The following is a description of a gene set: Human Gene Set: MEBARKI_HCC_PROGENITOR_FZD8CRD_UP studied in species Homo sapiens from publication Mebarki S, Désert R, Sulpice L, Sicard M, Desille M, Canal F, Dubois-Pot Schneider H, Bergeat D, Turlin B, Bellaud P, Lavergne E, Le Guével R, Corlu A, Perret C, Coulouarn C, Clément B, Musso O (PMID 27191501) Transcriptome of human HepaRG hepatocellular carcinoma liver progenitors in responses to a WNT3A-enriched microenvironment and dissection of pathways dependent on _-catenin and/or blocked by the SFRP-like Wnt inhibitor FZD8_CRD. Methods: Liver progenitor cells were incubated in a WNT-enriched microenvironment for 72hrs (200 ng/ml mouse recombinant purified Wnt3A from R&D Systems). Gene pathways dependent on downstream _-catenin were studied by _-catenin knockdown with specific siRNA. Gene pathways blocked by extracellular SFRP-like Wnt inhibitors were studied by co-incubating cells with recombinant purified FZD8_CRD (300 ng/ml, from R&D Systems). Independent culture experiments performed in triplicate include untreated cells or cells incubated with scrambled siRNA or with _-catenin-specific siRNA or with FZD8_CRD, alone or in combination with Wnt3A., and this is the list of marker genes: HJURP, HERC5, KIF24, FHDC1 (NCBI Gene Id 85462), ZWINT, BCL11B, BATF3, ILDR2, FAM111A, PLD5, WFDC21P, CENPE, FOXM1, FANCB, TUBBP2, PBK (NCBI Gene Id 55886), CHAF1A, NCAPD3, E2F1, CCR7, ENSG00000187951, RDM1, PSG2, CDKN3, H3C7, CKLF, MYB, CDC25B, RRM1, H2BC21, CIT, TUBG1, MAD2L1, OXR1, BLM, CDKL1, BARD1, VLDLR-AS1, KIFC1, NUP93, MBOAT1, NRGN, NLRP5, CACYBP, GINS2, SUV39H1, NCAPG2, DMBX1, ORC6, CDC6, TCF12-DT, UBASH3B, TMEM40, AURKB, CCNA2, CEP57L1, SKA1, PPP4R4, TRPA2P, UGCG (NCBI Gene Id 7357), POLE2, SASS6, MCUB, GDF15, BUB1, HMGB2 (NCBI Gene Id 3148), CRACDL, KIF20A, NIBAN1, PLAT, NR2F1-AS1, PHF19, TUBA1C, INPP5J, LINC00942, TP73, PTTG2, KPNA2, LRRC3, CKS2, EZH2, TAF1A, SAE1, PRIM2, DCLRE1B, BUB1B, LINC01704, ALG10, NEMP1, OIP5, RAD18, KNSTRN, DIAPH3, PAMR1, CCSAP, CSPG5, NCAPG, CCN3, PARD6G, WRAP53, NDE1, KIF15, TPX2, TMPO-AS1, ADORA2B, GNG12, GAREM2, SLC37A2, FKBPL, THSD1, RAD54L, MCM10, LRRC45, NSD2, GPSM2, HOXC9, RANBP20P (RAN binding protein 20 pseudogene), CKAP2L, PGM2L1, SEPTIN5 (septin 5), ADAM12, FBXO5, DNAJC9, KREMEN2, KIF2A, TRIM55, PHLDB1, FANCD2P2, PLK1, MEX3B, RNASEH2A, H4C4, ORC1, BRCA1, TIPIN, FAM72B, DDX11L2, TEDC2, SMS, SH3GL3, TLR6, CDC45, LRRIQ1, LINC02984, LINC01638, MTBP, TRAIP, LYPD6, TUBB8B, ATAD2, FANCM, ADAMTS5 (NCBI Gene Id 11096), PLEKHO1, TNFRSF8, SMTN, ARHGEF2, AK5, C10orf90, PSMC3IP, THAP10, PHTF2, PTTG1, ETV5, MTFR2 (NCBI Gene Id 113115), KIF2C, H4C14, BNC2, NUF2, SLC7A5, CDK2, LINC01173, ANXA3, ID3, CENPI, KMT5AP1, TAF5L, RFC2, ENSG00000266088 (novel transcript), LINC01111, CENPL, HNRNPDL, HASPIN, LMF2, TUBB6, CREB5, TOP2A, DDIAS, ESPL1, PACC1, FEN1P1, ARID3A, IL11, SEPTIN3, C4orf46, RGS9, TYMS, RNF7P1, VIM, SPC24, CKS1B, JPT1, ENSG00000288781, BRCA2, AUNIP, PLK4, H4C5, DEFB103B, SLC19A1, INCENP, MPHOSPH6, CENPP, PARPBP, H2AC10P, LOXL1, CENPO, CCNG2, KIF20B, PRMT2, TLE3, SCRN1, ARHGAP23P1, VRK1, DNMT3B, NUSAP1, MCM5, RCC2, TMSB15B, MYLK2, DEPDC1B, CHEK2, GPRIN1, FANCC (FA complementation group C), RANBP1, FIRRM, TK1, NUP155, UBE2T, H2AC16, H2AX, PANX2, CDCA4, CRISPLD2 (cysteine rich secretory protein LCCL domain containing 2), GAD1, NES, STIL, ATRIP, CASQ1, CDC20, LOXL3, ENSG00000289047, NECTIN1-DT, SPDL1, PRC1, TEDC1, ADGRB2, H2AC17, STXBP5, PSG9, MIS18BP1, H2BC7, ZNF669, SOCS2-AS1, SPTB, RRM2, LAYN, VEGFC, SLC5A11, MCM2, EXO1, CHRNA5, WDR1, C21orf58, PCMT1, C10orf88B, TICRR, HAUS8, RGS12, POLQ (DNA polymerase theta), UBE2SP2, E2F8, REEP1, C9orf40, CCDC134, SEM1, REXO5, MICB, CBX1P1, ARHGEF39, MYBL2, NUP62CL, SFN, LSM4, MDFIC, CHORDC1, SYCE2, CENPM, HAND2, POLA2, KLC2, PTTG3P, OR2T12, SLAMF7, MICALL1, SMC4, CSE1L, PSG6, KIF14, CALHM3, ERCC6L, CENPA, PRIM1, MICB-DT, RBL1, KIF22, LINC02901, GINS3, GNG4, NDC80, TCOF1, CENPH, ADISSP, ARHGAP19, MSH2, COTL1, LFNG, TMPO, MTHFD1L, MMS22L, GPR63, ASPM, ARSI, FAM72C, PSG3, YWHAH, CHAF1B, HMMR, KIF4A, NF2, ZEB2, LINC01722 (long intergenic non-protein coding RNA 1722), CORO1C, EEIG2, SKA3, DDX11, PCLAF, GTSE1, WDR62, SERPINB7, FGFR1, SP140, DONSON, ADAMTS8 (NCBI Gene Id 11095), PEA15, CATSPER1, AURKA, H3C14, TCF19, LIN9, NCAPD2, PSG5, RAD51B, SFTA1P, PRR11, FANCI, ELOVL2, CCP110, SUV39H2, H3C4, TRIP13, H2BC6, LMNB1, FANCA, CEP128, H1-5, NUP188, PDLIM3, RBM15-AS1, AFG2A, SLC7A11, RHEBL1, KNTC1, SLC44A2, ANOS1, TREX2, HK1, PAK6, PPP2R2C, GEMIN2P2, AOPEP, PTPRG-AS1, SLC13A3, LINC00941, MN1, MB21D2, CEP135, ANLN, FAM161A, PPP3R1, HROB, CEP76, HIRIP3, BCAS4, TFDP1, LMO7, CPA4 (NCBI Gene Id 51200), CSPG4P13, H3C10, RUNX1, RAD54B, LNP1, CCDC77, ATF3, FAM111B, RANGAP1, WDHD1, NRXN3, PPP1R18, PHACTR1 (NCBI Gene Id 81705), CDCP1, MYCL, CDK1, LRR1, TRIM59, ZNF681, G2E3, USP11, MCM7, FAAP24, ZWILCH, NIPAL3, TMEM237, CYTH4, CCDC80, MNS1, TROAP, ZNF385D, BCL2L12, JMJD1C-AS1, NTN4, DAW1, PKMYT1, RFC3, MYO3A, SPC25, SCML2, WDR76, RFWD3, MELK, CENPN, HBEGF, BDKRB1, LCOR, ADCY3, KLHL7, CDC25A, KIF23, RANP1, CDCA8, STMN1, UHRF1, TMSB15A, HAUS6, HPSE, DTYMK, BIRC5, CCDC169, PPM1F, MICAL3, IDS, NT5E, DHFR, CENPW, TIMELESS, TTK, CCDC74A, MKI67, ARNT2, IL17RD, TUBA1A, CFAP251, TACC3, RFC4, STK32B, STPG1, CHEK1, OXGR1, SCARA3, DIO2, OGFRL1, GEM, RAD51, NKAIN1, FMNL3, H2BW2, CCDC15, MND1, ECT2, INTS4 (NCBI Gene Id 92105), P2RX7, ASF1B, CENPQ, TONSL, KIF18A, TMEM74, RIBC2, NOX4P1, MTCL1, LRRCC1, MID1, MCM8, ERFE, CUZD1, HLX, POGLUT3, JPH1, GPR161, PKP3, ZYG11A, FSCN1, TEX30, AIDA, PCNA, DNA2, SGO1 (NCBI Gene Id 151648), MELTF, KNL1, SHCBP1, QRFPR, HMGA2, CCNB1, SCG5, KIF11, CCNF, SACS, NUP107, GINS1, TRABD2A, PML, ARHGAP31, AGPAT4, CDCA5, CEP55, CRABP2, FANCG, APCDD1L-DT, GPRC5A, TDP1, CRY1, CDCA7, CDC25C, TDRKH, CDC7, DLGAP5, GABPB1, WEE1, RBM24, PSRC1, KRT80, APCDD1L, LIG3, PXDN, EFR3B, FIG4, CEP97, ESCO2, CENPU, PLEKHG4, USB1, CEP78, CCNE2, CDCA3, ARHGAP11A, C8orf76, STYK1, TUBB4B, LINP1, LAMA1, WNT10B, RASD2, MZT1, DDAH1, PDE1C, TOP6BL, SGO2, NEK2, ACKR3, CDC42EP3, CCDC34 (NCBI Gene Id 91057), LY6K, FAM83D